Given this list of marker genes Ptpn22, Trim41, Ripk2, Chmp5, Nod1, Ldoc1, Vim, Nod2, Arhgef2, here is a description of the gene set: studied in species Mus musculus Any process that results in a change in state or activity of a cell (in terms of movement, secretion, enzyme production, gene expression, etc.) as a result of a muramyl dipeptide stimulus. Muramyl dipeptide is derived from peptidoglycan. Mouse Gene Set: GOBP_CELLULAR_RESPONSE_TO_MURAMYL_DIPEPTIDE